Given this list of marker genes RTN4, GRAMD4, IRAK4 (interleukin 1 receptor associated kinase 4), PPT1, HMGB1, PIK3AP1, FCRL3, IRAK1, RSAD2 (radical S-adenosyl methionine domain containing 2), EPG5, SLC15A4, TLR9, ZDHHC3, UNC93B1, RAB7B, NR1H4, LILRA4, TNIP2, HAVCR2, PTPRS, here is a description of the gene set: The series of molecular signals initiated by a ligand binding to the endolysosomal toll-like receptor 9. Human Gene Set: GOBP_TOLL_LIKE_RECEPTOR_9_SIGNALING_PATHWAY species: Homo sapiens